The following is a description of a gene set: Human Gene Set: GOBP_ESTABLISHMENT_OF_CELL_POLARITY studied in species Homo sapiens The specification and formation of anisotropic intracellular organization or cell growth patterns., and this is the list of marker genes: HDAC3, PRKCZ (NCBI Gene Id 5590), FAT1, KIF20B, WEE1, MYH9, CCDC66, KCNJ8, FRMD4B, TRAF3IP2, IFT20, ENKD1, INPPL1, BRSK1, RHOV, TTC8, NHERF1, HTT, PAX6 (NCBI Gene Id 5080), GATA3, EPHB1, DOCK8, SKA3, RICTOR (NCBI Gene Id 253260), SNX27, FRMD4A, AMOTL2, RUFY3, CFL1, ARFGEF1, PHLDB2, FLOT2, SHH, LLGL1, KIF25, FOXF1, UBXN2B, MISP, PLK1, GOLPH3, GPSM1, GPSM2, FERMT1, SLC9A6 (solute carrier family 9 member A6), MCPH1, SPAG5, TCF15, GSK3B, CRKL, FSCN1, ANKFN1, GBF1, CRB2, RHOQ, WNT7A, ABL1, SKA1, ARHGEF11, SHTN1, SCRIB, UST, GJA1, CYRIB (CYFIP related Rac1 interactor B), CDK5RAP2, ALPK2, ARF6, CYTH1, DIAPH3, ABL2, RAB11FIP2, FGF10, SKA2, CYTH3, FGF13, CRTAM, PLEKHG3, DOCK7 (dedicator of cytokinesis 7), HES1, KRIT1, SPDL1, PKHD1, RIPOR2, ROCK2, STK11, FBF1, DYNLT1 (NCBI Gene Id 6993), RHOU, FEZ1 (fasciculation and elongation protein zeta 1), JAM3, PTK7, CDH5, DOCK2, RAP1B, MAP4 (microtubule associated protein 4), CENPA, CCDC85C, BCCIP, OPHN1, WNT5A, CLASP1, LAMA1, PAK1 (NCBI Gene Id 5058), PTK2 (protein tyrosine kinase 2), BRSK2, WDPCP, PKD1, SIPA1L3, NSFL1C, GSN, ROCK1, NDE1, RAB10, PRICKLE1, MAP1B, MSN, MYO9A, CAMSAP3, MAD2L1, LLGL2, PARD3, SYNE4, SPRY2, RACK1, CORO7, DCTN1, CCL19, MARK2, FBXW11, KAT5, ZW10, CDC42, SDCCAG8, MOS, MYO18A, RAP2A, RHOA, AMOTL1, WWC1, EZR, NUMA1, TCIRG1, ITGB1, NDEL1, FOXJ1, RHOJ, NDC80, CRB1, CCL21, KANK1, CYP26B1, SH3BP1, AMOT, MAPRE1, KIF26B, CCR7, SPRY1, CRK, PRKCI (NCBI Gene Id 5584), SAPCD2, PATJ, PAFAH1B1, PARD3B, FAM89B, HES5, MPP7